The following is a description of a gene set: The process in which the neural fold is formed. The edges of the neural plate thicken and move up to form a U-shaped structure called the neural groove. species: Mus musculus Mouse Gene Set: GOBP_NEURAL_FOLD_FORMATION, and this is the list of marker genes: Hif1a, Bmp7, Ovol2, Luzp1, Gatad2a, Nodal, Cfl1, Bmp5, Cecr2